Given this list of marker genes ST6GAL1, TRIB2, POU2AF1, TNFRSF13B, TRIB3, PRKCB, ITGA7, ZNF668, TSHZ2, TEC, DHCR7, DAPL1, EXT1, HMGN3, WFS1, TOX, IFT25, AFF3, DYNLT2B, DLGAP5, TCF7, PACSIN1, AHI1, LRIG1, LYPD6, UBQLN2, HSDL1, CDC42EP4, RIPOR2, FARP1, NIPAL1, CABCOCO1, TNFRSF9, KLHDC2, TWSG1, ZNF24, GPM6B, BMP2K, ATP1B1, EGR2, RAB20, PDE4B, P2RX7, FCRL1, GPR146, RAB3IP, CST7, ART3, RNF19A, IZUMO1R, GPCPD1 (glycerophosphocholine phosphodiesterase 1), PPIC, EID2, PRICKLE1, DPP4, ARHGAP5, ADK, RGS10, GCNT1, GLTP, PHTF1 (NCBI Gene Id 10745), LRRC42, MMD, PRNP, ATP6V1D, MFHAS1, CCDC126, F2RL1, TBC1D19, NEDD4L, TGIF2, IL6ST, ST8SIA6, MYB, ACTG2, SLC25A14, EPHX1, ANGPTL6, ACTN1, AGL (NCBI Gene Id 178), UBASH3B, ARHGAP29, TRMT112, SLC43A1, ZC4H2, TSPAN32, PANK1, SALL2, TAGAP, SLAMF6, SHLD1, FAM210A, ZNRD2, KRT10, CEP72 (centrosomal protein 72), TIMP2, ZFR2, LSR, DUSP10 (NCBI Gene Id 11221), IGF1R, TFCP2, CYB5B, PPP1CB, AGFG1, KCNMB4, LITAF, CHAC2, TRIP12, ING1, EOMES, CERS6, MYO6, CXCR4, MCL1, TRAF5, CXCR5, RTCA, PIGK, RPA1, ANGPTL2, TRAPPC9, IFT57, ACSL3, IMMP2L, TPD52, CYTH3 (cytohesin 3), ZC3H6, CUL2, MSRB2, SESTD1, SNN, MPP1, KCNC2, FAM118A, RPL31, HLA-DOB, THEMIS (NCBI Gene Id 387357), LDHB, NUCB2, ZSWIM5, MAP3K4 (mitogen-activated protein kinase kinase kinase 4), CTSV, GRHL1, NMB, TSPAN13, EGLN3, RFLNB, DEAF1, SMPDL3A, USP28, NR3C2, DYNC2LI1, RUNDC3B, PDK1, SFMBT2, ASAP1, ASAH2, CD200, LIPA, CTSS, MATK, TSPAN3, HIF1A, BBS10, MTMR4, CEMIP2, CCR7, GLIS3, EGR3, WDFY2, TMEM218, DECR1, MCCC2, DCAF11, AFTPH, TGFBR3, SPRED1, TOX2, SMYD2, PPTC7, RAMP3, DNAJC6, MCUR1, IBA57, PHF2, USP6NL, LDLRAP1, ELP1, CNGA1, CBX6, ATP6AP2, NME4, SEMA7A (NCBI Gene Id 8482), APOBEC2, CD81, RNF32, OSBPL9, EPB41L5, PHACTR2, here is a description of the gene set: Discrimination between self vs. non-self and adequate response to infection and tissue damage are fundamental functions of the immune system. The rapid and global spread of known and emerging viruses is a testament that the timely detection of viral pathogens that reproduce within host cells, presents a formidable challenge to the immune system. To gain access to a proper reproductive niche, many pathogens travel via the host vasculature and therefore become exposed to humoral factors of the innate immune system. Although a cascade of coagulation factors plays a fundamental role in host defense for “living fossils” such as horseshoe crabs (Xiphosurida spp), the role of the coagulation system in activation of innate responses to pathogens in higher organisms remains unclear. When human type C adenovirus (HAdv) enters the circulation, 240 copies of coagulation factor X (FX) bind to the virus particle with picomolar affinity. Here, using molecular dynamics flexible fitting (MDFF) and high resolution cryo-electron microscopy (cryo-EM), we defined the interface between the HAdv5 hexon protein and FX at pseudo-atomic level. Based on this structural data, we introduced a single amino acid substitution, T424A, in the hexon that completely abrogated FX interaction with the virus. In vivo genome-wide transcriptional profiling revealed that FX-binding-ablated virus failed to activate a distinct network of the early response genes, whose expression depends on transcription factor NFKB1. Deconvolution of the signaling network responsible for early gene activation showed that the FX-HAdv complex triggers MyD88/TRIF/TRAF6 signaling upon activation of toll-like receptor 4 (TLR4) that serves as a principal sensor of FX-virus complex in vivo. Our study implicates host factor “decoration” of the virus as a mechanism to trigger innate immune sensor that respond to a misplacement of coagulation FX from the blood into intracellular macrophage compartments upon virus entry into the cell. Our results further the mounting evidence of evolutionary conservation between the coagulation system and innate immunity. Genes down-regulated in Lung dendritic cell from Ad5 infection wildtype mice versus Lung dendritic cell from Ad5 inf IL-1R mice. species: Homo sapiens from publication Doronin K, Flatt JW, Di Paolo NC, Khare R, Kalyuzhniy O, Acchione M, Sumida JP, Ohto U, Shimizu T, Akashi-Takamura S, Miyake K, MacDonald JW, Bammler TK, Beyer RP, Farin FM, Stewart PL, Shayakhmetov DM (PMID 23019612) Human Gene Set: GSE36078_WT_VS_IL1R_KO_LUNG_DC_AFTER_AD5_INF_DN